Given this list of marker genes IGF1R, BMPR1B, TRAV35, TRAV1-1, EMILIN1, TRAV8-2, GP1BB, CHRNA1, TRBV7-9, ITGA2, GRIK3, TRBD1, IGHM, TFR2, GRIN2B, TRBJ2-4, CACNG7, TRGV8, HFE (homeostatic iron regulator), BMPR1A, CACNG3, IL6, TRAV23DV6, TRGV4, ACVR2A, ITGA11, TRAV38-1, ITGA6, TRAT1, ITGBL1, TRBV6-8, TRBV29-1, TRAV41, TRBV25-1, TRAV34, GRIA3, ZAP70, TRAV25, TRBV10-2, ITGA3, CHRFAM7A, VWC2L, RAMP1, IL2RB, ITGAL, HTR3A, GABBR2, TRBJ1-4, HTR3D, LIME1, TRBV10-3, HJV, TRAV39, TRAJ3, TRBV30, CD40, B2M, TRBJ2-7, GABBR1, TRBV7-2, CSF2RB, TF, TRBC1, CHRNA6, LYN, BIRC2, SACM1L, TRBJ2-1, TRDV3, TRGC2, TRAV16, TRBV7-4, HTRA2, HTR3B, TRBJ2-3, TRAV12-3, TRAV29DV5, ITGAD, CNIH3, ITGAV, ITGAE, ITGAX, TRAV4, ITGB2, CHUK, TGFBR1, GRIN1, TRAC, TRBV3-1, CD79B, CACNG4, TRBJ1-2, ITGA10, TRBV14, TRAV22, TRBV2, IL23R, TRBV7-7, TYK2, CHRNB2, IL18RAP, CHRNB1, GRIK4, IL6R, IRS1, PTPN6, CHRND, TRDC, TRAV6, GRID1, APBB1IP, OLFM3, TRAF2, TRBV9, TRBV19, TRBV28, RAMP2, OLFM2, CSF2, TRAV20, ITGA1, TRBJ2-2, TRBV16, TLR1, ITGA7, TRAV17, TRBV4-1, CD8B, TRBV11-1, GRIA1, TRBJ1-5, CHRNA3, ITGB3, DLG3, SHISA9 (shisa family member 9), TRGV3, OSMR, ITGA8, CD79A, CD6, PORCN, TRAV10, TRAV38-2DV8, TRBV18 (T cell receptor beta variable 18), TRBV5-7, GRID2, TRAV8-6, INSR, TRAV30, CALCR, ALCAM, TRGV5, TRGV1, TRBV27, ACVR1B, TRBJ1-3, IL6ST, TRBV12-4, TRAV3, TRAV8-3, CD247 (CD247 molecule), TRAV13-1, CHRNA4, TRAF3, ACVR1, ITGA2B, PTK2B, CD8A, SDCBP, GRIN2C, GRIK2 (NCBI Gene Id 2898), TRAV14DV4, ITGB7, TRAV7, TRBV5-1 (NCBI Gene Id 28614), TRBJ2-6, TRBJ1-6, CD3G, TRAV13-2, TRBV10-1, TRBV6-6, TRBV13 (T cell receptor beta variable 13), TRBV12-3, TRBV20-1, JAK2, TRBV6-5, CNTFR, GRIK5, TRAV5, TRBV24-1, INSRR (insulin receptor related receptor), ITGAM, TRBC2, IFNL1, SHISA6, TLR2, NRN1, TRAV40, CD4, ITGB5, TRAV9-1, DRD2, GRM1, SHISA7, TGFBR2, TLR6 (toll like receptor 6), ACVR1C, TRAV1-2, TRDD1 (NCBI Gene Id 28525), ITGB8, ABHD6, TRAV12-1, CHRNG, IKBKB, TRDV1, TRAV9-2, GRIN3A, PSG9, TRBV17, CPT1C, IL18R1, TRAV8-1 (T cell receptor alpha variable 8-1), TRBV12-5, TRBJ1-1, ERBB3, BMP2, TRAF6, SYK, ABHD12, TRBV7-3, CHRNA2, TSPAN32, TRGV2, GRIK1, TRGV11, TRBV7-6, TRAV2, TRAV19, TRBV6-7, TRBV5-6, FLNA, GP9, DLG4, TRGC1, TRAV18, GP1BA, TRBV11-2 (T cell receptor beta variable 11-2), VWC2, CHRNA7, IL13RA1, IL12RB1, TRBV6-4, TRGV10, CHRNB3, CHRNA9, CD3E, ITGA9, TRAV21, HTR3C, ACVR2B, SKAP1, TRAV36DV7, TRAV26-2, TRBV4-2, TRAV8-4, RAMP3, GP5, GRIN3B, GPR156, GRIA2, RNF31, DRD1, EPS8, CHRNA5, ITGA5, IGHE, CHRNE (NCBI Gene Id 83405, cholinergic receptor nicotinic epsilon subunit), TRBV11-3, CEACAM1, CD3D, IL10RB, TRBV6-1, TRBV23-1, ITGA4, CSF2RA, HTR3E, IFNLR1, TRAV12-2, ACVRL1, CACNG8, CACNG5, TRAV24, DIABLO, GRIN2D, CACNG2, SHISA8, CALCRL, TRBV7-1, TRBV5-3, TRBV5-4, GRIN2A, STXBP5, IL2RA, CHRNB4, GRIA4, TRDV2, TFRC, TRAV27, CNIH2, TRBV5-5, TRGV9, ITGB4, ITGB1, TRDJ1, TRAV26-1, ERBB2, ITGB6, TRBJ2-5, TRAF5, here is a description of the gene set: species: Homo sapiens Any protein complex that is part of the plasma membrane and which functions as a signaling receptor. Human Gene Set: GOCC_PLASMA_MEMBRANE_SIGNALING_RECEPTOR_COMPLEX